The following is a description of a gene set: Combining with a semaphorin, and transmitting the signal from one side of the membrane to the other to initiate a change in cell activity. studied in species Mus musculus Mouse Gene Set: GOMF_SEMAPHORIN_RECEPTOR_ACTIVITY, and this is the list of marker genes: Plxnc1, Plxnb3, Nrp1, Plxna2, Plxnb1 (plexin B1), Plxna3, Plxna4 (plexin A4), Plxnb2, Trem2, Plxna1, Met, Plxnd1, Nrp2